Given this list of marker genes TP73, TIMP3, RBP1, CDKN2A, CDKN2B, RARB, SFRP4, SFRP5, here is a description of the gene set: from publication Ohm JE, McGarvey KM, Yu X, Cheng L, Schuebel KE, Cope L, Mohammad HP, Chen W, Daniel VC, Yu W, Berman DM, Jenuwein T, Pruitt K, Sharkis SJ, Watkins DN, Herman JG, Baylin SB (PMID 17211412) Genes with low to medium basal transcription state in undifferentiated embryonic carcinoma cells. Human Gene Set: OHM_EMBRYONIC_CARCINOMA_DN studied in species Homo sapiens Adult cancers may derive from stem or early progenitor cells. Epigenetic modulation of gene expression is essential for normal function of these early cells but is highly abnormal in cancers, which often show aberrant promoter CpG island hypermethylation and transcriptional silencing of tumor suppressor genes and pro-differentiation factors. We find that for such genes, both normal and malignant embryonic cells generally lack the hypermethylation of DNA found in adult cancers. In embryonic stem cells, these genes are held in a 'transcription-ready' state mediated by a 'bivalent' promoter chromatin pattern consisting of the repressive mark, histone H3 methylated at Lys27 (H3K27) by Polycomb group proteins, plus the active mark, methylated H3K4. However, embryonic carcinoma cells add two key repressive marks, dimethylated H3K9 and trimethylated H3K9, both associated with DNA hypermethylation in adult cancers. We hypothesize that cell chromatin patterns and transient silencing of these important regulatory genes in stem or progenitor cells may leave these genes vulnerable to aberrant DNA hypermethylation and heritable gene silencing during tumor initiation and progression.